The following is a description of a gene set: Genes predicted to be targets of miRBase v22 microRNA hsa-miR-1206 in miRDB v6.0 with MirTarget v4 prediction scores > 80 (high confidence targets). studied in species Homo sapiens Human Gene Set: MIR1206 from publication Chen Y, Wang X (PMID 31504780), and this is the list of marker genes: SKA3, CDH11, SPAG9 (sperm associated antigen 9), TAOK1, RHOQ, FIGN, CPEB2, DENND1B, WDR41, C9orf85, ATXN7, KLHL32, TBC1D19, P2RX2, TMEM259, SLC4A5, BRINP3, USP32, EBF2, CRISPLD2 (NCBI Gene Id 83716), KPNA4, KCNB2, LRRC31, STXBP3, HOXA1, TMEFF1, MEF2A, VAPA, KLHL2, HNMT, NOS3, VSTM4, NEDD4L, PTPN13, MFSD14A, GRIK2, ORC4, TPBG, PPARGC1A (NCBI Gene Id 10891), MSANTD3-TMEFF1, ZNF805, EFCAB9, GASK1A, DSCC1, DCUN1D4, KIF2A, EPRS1, IDH3A, SNTG1, SERTAD4, CAP2, KCNJ2, GSTM4, SF3B3 (NCBI Gene Id 9661), ZNF207, ANKRD12, PPDPFL, C4A, APC, EIF1AY, C4B, KRAS (KRAS proto-oncogene, GTPase), PRKCB, SOX6, C1GALT1C1, ZC3H6, SEMA6A, SMNDC1, ASAP2, ARHGAP21, PANK2, TPD52L3, NDNF, KCND2, CLIC4, THRB, PTPN7, SMIM19, THSD7B, REV1, SEC23A, FZD3, ATP2A2, EBF3, C5orf24, CDK19, MOB1B, CLVS1, ATXN2, ZMYM6, DOK6, ANOS1, CEP135, FOXD4L5, TSC22D2, MAP9, ADCY1, PI4K2B, FOSL2 (FOS like 2, AP-1 transcription factor subunit), PRKAG2 (NCBI Gene Id 7981), TIMP3, NR5A2, UBE3A, ENTPD5, KCNQ5, SH3BGRL, LRP1B, DDI2, FUT8, YWHAZ, MTMR14, CERT1, FLG2, SAR1A, PLEKHA1, SHISA3, PTGES3